The following is a description of a gene set: Human Gene Set: WP_STATIN_INHIBITION_OF_CHOLESTEROL_PRODUCTION species: Homo sapiens Statin inhibition of cholesterol production, and this is the list of marker genes: ABCG5, APOE, LCAT, SQLE, CYP7A1, MTTP, APOA5, APOB, HMGCR, LRP1, LPL, LDLR, LIPC, APOC2, MIR33B, ABCG8, FDFT1, MIR33A, ACSS1, SOAT1, APOA2, CETP, ABCA1, APOC3, APOA1, SCARB1, APOA4, PLTP, DGAT1, PDIA2, APOC1